Given this list of marker genes ADGRG1, GAS5, BRD7, TBX1, ADAMTSL4-AS1, ZCCHC24, SLC16A5, KHDC4, KLHDC9, ZNF200, SMG1, STAT6, SMARCD2, CCDC9, ARL6IP1, ERICH6, PRR14, RNVU1-26, CACTIN, ERICH6-AS1 (ERICH6 antisense RNA 1), RNVU1-30, THA1P, WDR24, MIR5087, SLC39A3, TSC22D4, H2BC18, RNVU1-4, EBAG9, here is a description of the gene set: Genes containing one or more binding sites for (THRAP3) in their promoter regions (TSS -1000,+100 bp) as identified by GTRD version 20.06 ChIP-seq harmonization. Human Gene Set: THRAP3_TARGET_GENES from publication Yevshin I, Sharipov R, Kolmykov S, Kondrakhin Y, Kolpakov F (PMID 30445619) studied in species Homo sapiens